The following is a description of a gene set: Human Gene Set: HOXA7_TARGET_GENES studied in species Homo sapiens from publication Yevshin I, Sharipov R, Kolmykov S, Kondrakhin Y, Kolpakov F (PMID 30445619) Genes containing one or more binding sites for (HOXA7) in their promoter regions (TSS -1000,+100 bp) as identified by GTRD version 20.06 ChIP-seq harmonization., and this is the list of marker genes: HIKESHI, DIS3, ZMPSTE24, TMEM123, MVB12A, TCAIM, INO80B, RBBP4, GRPEL2, RBBP5, DNMBP, ELOF1, SBNO1-AS1, INO80B-WBP1, TPR, COPS2, VARS2, PJA2, BLOC1S6, PPIL3, H2AX (H2A.X variant histone), ANAPC5, CSNK1A1, NIF3L1, FPGS, BISPR, EIF3B, GTF2H4, PPP1R11, BST2, GLI1, LACTB, SDHAF4, OGA, UTP3, NR1D1, MIRLET7IHG, PCLAF (NCBI Gene Id 9768), ZNF33A, STXBP3, ZBTB8OS, FNTB, ARHGEF37, RBCK1, ZFP91-CNTF, SNORA80B, HIGD2A, FEM1A, HPGD, ZFP91, RNF34, RPL41, YARS2, ERCC1, HDGF, MAPK6, POM121, CACYBP, ENSG00000261118 (NCBI Gene Id 101927863), SCAND3 (SCAN domain containing 3), PSMD8, GABPB1, BLCAP, LYRM7, SAMM50, SPATS2L, PCNX3, ZMPSTE24-DT, LTA4H, DNAJC28, NOP16, EPS8, AKT1S1, ABCF2, ADK, AP3M1, MAP3K11, DNAJC24, GABPB1-AS1, TBC1D17, DEPDC1B, DNAJB4, DCDC1, ODR4, LPXN, KCNIP2-AS1, COASY, NDUFAF4P1, FZR1, PPP2R5E, MTUS1, RAD52, PIERCE2, TMEM123-DT (TMEM123 divergent transcript), RNU11, RAD23B, DDR1, EIF4A2, REG4, ZBTB45, KANSL2, ZNF627, MRPL24, NWD1, DLG4, RPL37 (NCBI Gene Id 6167), TRIM4, UNK, PRCC, WDR33, ACADVL, TCEANC2, SLC28A2-AS1, GCNT3 (NCBI Gene Id 9245), TMEM59, PIKFYVE, SNX8